Given this list of marker genes TIMM23, SAMM50, TOMM70, ROMO1, TOMM22 (NCBI Gene Id 56993), TOMM20, TIMM17A, DNLZ, DNAJC15, TOMM40L, TIMM21, TOMM40, GRPEL2 (NCBI Gene Id 134266), TOMM20L, TOMM7, TIMM17B, TIMM44, DNAJC19, GRPEL1, HSP90AA1, TIMM23B, PAM16, HSPA4, TIMM50, here is a description of the gene set: The import of proteins across the outer and inner mitochondrial membranes into the matrix. Unfolded proteins enter the mitochondrial matrix with a chaperone protein; the information required to target the precursor protein from the cytosol to the mitochondrial matrix is contained within its N-terminal matrix-targeting sequence. Translocation of precursors to the matrix occurs at the rare sites where the outer and inner membranes are close together. species: Homo sapiens Human Gene Set: GOBP_PROTEIN_IMPORT_INTO_MITOCHONDRIAL_MATRIX